The following is a description of a gene set: Genes predicted to be targets of miRBase v22 microRNA hsa-miR-4682 in miRDB v6.0 with MirTarget v4 prediction scores > 80 (high confidence targets). from publication Chen Y, Wang X (PMID 31504780) Human Gene Set: MIR4682 species: Homo sapiens, and this is the list of marker genes: ELAVL4, MDGA2, STAMBP, PEG3, NRIP1, HSP90AA1, FUT8, DSG2, MLH3, SYNE2, YWHAB, EEA1, PRKCE, ZNF597, OPRK1, ZDHHC17, CREB5, TNFSF14, ATG2B, JCAD, NOL4L, GIPC3, CCNJ, SPRING1, RBM27 (RNA binding motif protein 27), CYP3A43, EN2, DTX3L, RTN3, BCCIP, SLC39A14, ICA1L, UNC5D, ITGA2, ZNF146 (NCBI Gene Id 7705), KMT2D, CAND2, CLVS2, TRAF3IP3, SP8, PRDM16, SYNJ1, TMEM40, PDE3A, DMD, IER3, PLPPR5 (NCBI Gene Id 163404), TLL2, SLC45A3, POLG, CDH7 (NCBI Gene Id 1005), PPP3R1, STAT1, GPR34, PITRM1, DERL2, TGFB2, VGLL3, QKI, SKIDA1, GATC, ATCAY, TOR2A, ESRRB, NCBP2, EBF1, SEL1L, ASAP2, GALNT2, USP8, CYP4F22, MAOA, NDUFB8, CAMLG, CELF4, ATE1, FBXL2 (NCBI Gene Id 26008), PHF20L1, IARS1, ZNF30, ERLIN1, PLPP1, SEMA5A, GRIA4, C1QTNF1, FGF14, LRRC34, R3HDM1, PARVA, ZDHHC15, SFXN1, OSGIN2, PLPPR4, DENND6A, CDH4, MRPS2, M1AP, CLK4, SATB2, PIKFYVE, PPP6C, WDFY2, PARPBP, ZC3H7A, OC90, IRF2, NFXL1, STK4, KLHL14, CKLF, BEST1, PLCH1, IQCH, THAP2, RAP2C, C2CD6, ELP1, KLHL9, QSER1, CFAP97, SEMA6A, INSR, KLHL34, BMAL2, TMOD2, CPEB4, CBY2, EVI2A, RBM41, MAP7, LCLAT1, USP31 (ubiquitin specific peptidase 31), DTWD2, ZKSCAN8